Given this list of marker genes PPP2R5D, PFKFB1, PPP2R1A, PPP2CB, PFKFB3, PFKFB2, PFKFB4, PPP2R1B, PPP2CA (protein phosphatase 2 catalytic subunit alpha), PRKACA, PRKACG (NCBI Gene Id 5568), PRKACB, here is a description of the gene set: species: Homo sapiens Regulation of glycolysis by fructose 2,6-bisphosphate metabolism Human Gene Set: REACTOME_REGULATION_OF_GLYCOLYSIS_BY_FRUCTOSE_2_6_BISPHOSPHATE_METABOLISM